Given this list of marker genes KCNJ2, KCNJ5, KCNE3 (NCBI Gene Id 10008), CDH23, CA2, GABRA3, SCN4A, CACNA1S, KCNJ18, here is a description of the gene set: Periodic hypokalemic paresis Episodes of muscle weakness associated with reduced levels of potassium in the blood. studied in species Homo sapiens Human Gene Set: HP_PERIODIC_HYPOKALEMIC_PARESIS